The following is a description of a gene set: Human Gene Set: HP_CLONIC_SEIZURE Clonic seizure A clonic seizure is a type of motor seizure characterized by sustained rhythmic jerking, that is regularly repetitive. species: Homo sapiens, and this is the list of marker genes: SMARCAL1, CASK, PRRT2, PCDH12, RNH1, HCN1, DMXL2, DNM1, ATP6V1A, FRRS1L, ATP1A2, PCDH19, ATP6V0A1, RELN, CDKL5, SCN1A, KIF5C, KCNK4, PNKP, DENND5A, KCNH5, FZR1, MICAL1, WWOX (WW domain containing oxidoreductase), NAGS, SLC25A22, KIF5A, ACSF3, SLC32A1, TBC1D24, NEUROD2, PLPBP, GRIN1, SRPX2, SCN3A, KANSL1, GRIK2, SATB1, GRIA2, ST3GAL3, ADAM22, TRIM8, GLYCTK, SLC12A5, PIGA, COX11, ALDH7A1, ATP1A3, SCN8A, PLCB1, SCN1B, CRELD1, GNAO1, GABRG2, GRIN2A (glutamate ionotropic receptor NMDA type subunit 2A), PACS2, KCNA1, DPM2, PIGP, GRM7, KCNQ3, NAPB, PEX3, SCN9A, SPTBN1, CUX2, ARX, UFSP2, GABRA1, SCN2A, TPK1, LGI1, COQ4, KCNQ2, CACNA2D1, PIGQ, SIK1, PSAP, ASNS, KCNT1, GABBR2, GLUL, GNB1